The following is a description of a gene set: Mouse Gene Set: REACTOME_DOPAMINE_NEUROTRANSMITTER_RELEASE_CYCLE studied in species Mus musculus Dopamine Neurotransmitter Release Cycle, and this is the list of marker genes: Unc13b, Syn3, Apba1, Slc18a2, Syn2, Cplx1, Stxbp1, Lin7b, Ppfia1, Snap25, Syt1, Stx1a, Rab3a, Rims1, Lin7c, Tspoap1, Vamp2, Lin7a, Syn1, Ppfia4, Ppfia2, Cask, Ppfia3